Given this list of marker genes Dnhd1, Rilpl1, Rilpl2, Dync1h1, Dnah2 (dynein, axonemal, heavy chain 2), Hook3, Dnah17, Rab11fip3, Ccdc88a, Dnah7b, Dnah3, Dnah14 (dynein, axonemal, heavy chain 14), Dnah8, Dnah9, Dync2h1, Dnah6, Dnah12, Hook1, Dnah7c, Rab11a, Ccdc88c, Dnah1, Dnah7a, Ccdc88b, Dnah11, Dnah5, Rilp, Hook2, Dnah10, Bicd2, here is a description of the gene set: Mouse Gene Set: GOMF_DYNEIN_LIGHT_INTERMEDIATE_CHAIN_BINDING species: Mus musculus Binding to a light intermediate chain of the dynein complex.